The following is a description of a gene set: Catalysis of an oxidation-reduction (redox) reaction in which the hydrogen donor and acceptor are the same molecule, one or more carbon-carbon double bonds in the molecule are rearranged, and no oxidized product appears. studied in species Homo sapiens Human Gene Set: GOMF_INTRAMOLECULAR_OXIDOREDUCTASE_ACTIVITY_TRANSPOSING_C_C_BONDS, and this is the list of marker genes: EBP, ECI2, ECH1, ECI1, EBPL, ECHS1, HSD3B1, DDT, IDI1, EHHADH, GSTA1, SREBF2, IDI2, MIF, DCT, HSD3B2